Given this list of marker genes Mir124a-3, Cdon, Bex1, Dlx1, E2f1, Tbc1d24, Rufy3, Cdkl5, Pias2 (NCBI Gene Id 70728), Gjc2, Slc30a1, Plxnb3, Il6, Csf1r, Rb1, Lrp1, Mir124a-2, Kit, Efna5, Vsx2, Hes3, Wnt3a, Brinp1, Serpinf1, Bmal1, Mfn2, Ptprd, Nf2, Smo (smoothened, frizzled class receptor), Heyl, Lig4, Trim46, Prl2c2 (NCBI Gene Id 18811), Man2a1, Igf1, Tle6, Zfp365, Dpysl5, Map2, Mbd1, Lhx2, Map2k1, Faim, Caprin1, Nrp1, Mbp, Notch1, Il1rapl1 (NCBI Gene Id 76162), Numb, Slit2, Lrp2, Spint1, Pitx3, Trf, Sema4d (sema domain, immunoglobulin domain (Ig), transmembrane domain (TM) and short cytoplasmic domain, (semaphorin) 4D), Rest, Map2k2, Cdh1, Nf1, Foxg1, Tnr, Camk2b, Dnajb11, Wnt5a, Ntf3, Rnf6, Fxr2, Idh2, Hmgb2, Atoh1, Cdkl3, Fbxw8, Hes6, Fgfr3 (fibroblast growth factor receptor 3), Cul7, Prune1, Robo1, Cux1, Tnfrsf12a, Bhlhe40, Helt, Epha4, Trim32, Obsl1, Pou4f2, Golga4, Nrdc, Sema6c, Bmp7, Il34, Map1b, Sema4f, Plxnc1, Fas, Dnm1l (dynamin 1-like), Adnp, Snap91, Vegfa, Sema3g, Gli3, Ufl1, Zeb2, Rheb, Tiam2, Stk25, Ezh2, Anapc2, Dlx2, Cx3cr1, Hey1, Disc1, Mycn, Dhx36, Xrcc4, Ngf, Map3k13, Ss18l1, Spart, Atxn1, Jade2, Sox10, Nkx6-1, Sorl1, Ep300, Itgb1, Lif, Ptpra, Psen1, Adcyap1, Trp73, Tmem98, Myb (NCBI Gene Id 97674), Enpp2, Pcm1, Nog, Wnt7a, Sema3f, Rela, Twf2, Rgma, Nrg1, Prpf19, Ascl1, Tiam1, Cers2, Gsx2, Rpl4, Ntrk3, Kdr, Bhlhe41 (NCBI Gene Id 79362), S100a10, Dcx, Arrb2, Hes1, Sox11, Ifng, Ctnnb1, Dll4, Nkx6-2 (NCBI Gene Id 14912), Actr3, Trpc5 (NCBI Gene Id 22067), Sh3glb1, Lpar3, Dag1, Golga2, Oprm1, Neurl1a, Ptprs, Smurf1 (SMAD specific E3 ubiquitin protein ligase 1), Cxcl12, Trp53, Lingo1, Mme, Rtn4r, Nfatc4, Nkx2-2, Cysltr1, Met, Slc7a5, Cask, Tert, Atf5, Ascl2, Ndel1, L1cam, Stk11, F2, Fn1, Pak3, Hap1, Ephb2, Cdk5, Arhgap32, Hmga2, Rapgef2, Fstl4, Nos1, Ntrk2, Ulk1, Tnfrsf1b, Baiap2, Xrcc6, Sirt2, Kdm4a, Spen, Ist1, Plxnb1, Vegfc, Fzd4, Mir23a, Dbn1, Ferd3l, Ifrd1, Per2, Ctnna1 (catenin alpha 1), Tlr2, Arhgef2 (NCBI Gene Id 99482), Adcy10, Ythdf2, Ldlr, Fezf2, Picalm, Id2, Rab21, Gata2, Sema3a, Mir219a-1, Pak1, Dct, Lta, Appl2, Fmr1, Trpv2, Dab1, Clcf1, Tnf, Kctd11, Afdn, Gpr37l1, Mfn1, Reln, Xrcc2, Braf, Nptn, Eef2k, Tenm4, Pten, Myrf, Mup20, Gorasp1, Sox8, Fzd3, Egfr (NCBI Gene Id 13649), Sox2, Khdc3, Yap1, Tspo, Fgf2, Slitrk1, Syngap1 (NCBI Gene Id 638978), Zfyve27, Wnt2, Snw1, Gfap, Xrcc5, Dll3, Hdac6, Cip2a, Olig2, Btg2, Rgs14, Id4, Clcn2, Myc, Rnf10, Stau2, Tgfb1, Il1b, Cux2, Daam2, Ace, B2m, Grip1, Map6, Cdkn2b, Lin28a, Cxcr4, Wls, Mapt, Shh, Sgk1, Plxnb2, Cx3cl1, Ppp3ca, Mt3, Bmpr1a, Tnik, Trak2, Pou4f1, Dmrta2, Ccr5, Star, Hes2, Trpc6, Megf8 (NCBI Gene Id 269878), Il6st (NCBI Gene Id 71317), Ctf2, Tsc2, Macf1, Dock7, Abcc8, Ptk2, Rassf10, Arhgap4, Bmpr2, Bcl11a, Sema6d, Anxa2, Kalrn, Hey2, Zfp488, Kras, Crabp2, Srf, Hdac1, Pafah1b1, Tlx2, Eif2b2, Epha7, Xlr3b (NCBI Gene Id 574437), Syt4, Wdr62, Chd7, Amigo1, Drd2, Efnb3 (ephrin B3), Fezf1, Prox1, Prkch, Serpine2, Ilk, Plag1, Ccl11, Pparg, Bag1 (NCBI Gene Id 12017), Hes5, Mtor, Mir219a-2, Shox2, Itpka (NCBI Gene Id 228550), Dlg4 (NCBI Gene Id 13385), Id1, Cd24a, Nefl, Ptn, Wnt3, Thy1, Akap5, Bmp4, Parp6, Caprin2, Trem2, Dscam, Eif4g2, Ttc3, Dusp10, Rnf112, Ptprz1, Wnt7b, Fxn, Drd3 (NCBI Gene Id 13490), Actr2, Dixdc1, Egr2, Tgm2, Plxnd1, Plxna3, Mapk8, Mir124a-1, Draxin, Slit1, Flt1, Hltf (helicase-like transcription factor), Etv5, Ache, Ywhah, Trim11, Aspa, Ell3, Hdac2, Marcks, Nin, Hoxb3, Nap1l1, Mecp2, Gper1, Prtg, Nkx2-2os, Casz1, Opa1, Ryk, Sema5a, Lrp4, Cdh4, Robo2, Srrt, Hif1a, Kifap3, Synj1, Pax6, Nr2e1, Shank3, Rnd2, Mdk, Cysltr2 (cysteinyl leukotriene receptor 2), Limk1, Aspm, Islr2, Dicer1, Apoe, Kdm1a, Bhlhb9, Ppp1cc (NCBI Gene Id 627816), Ulk2, Ski, Ntn1, Rtn4, Trak1, D130043K22Rik, Dip2b, Prmt5 (protein arginine N-methyltransferase 5), Lyn, Zfp335, Lef1, Nr1d1, Metrn, Prkci, Grm5, Shtn1, Vax1, Bmp2, Qki, Bin1, Fxr1, Dynlt1b, Zcchc24, Dbnl, Chodl, Cit, Smarcd3, Skil, Dll1, Sema7a (NCBI Gene Id 78407), Numbl, Ctdsp1, Bdnf, Hes7, Otp, Mag, Fgf13, Gsk3b, Vim, Lrp8, Fbxo31, Ptprf, Ankrd27, Gdi1, Myo5b, Gh, Cyfip1, Il33, Hook3, here is a description of the gene set: Mouse Gene Set: GOBP_REGULATION_OF_NEUROGENESIS Any process that modulates the frequency, rate or extent of neurogenesis, the generation of cells in the nervous system. studied in species Mus musculus